The following is a description of a gene set: studied in species Homo sapiens Human Gene Set: GOBP_ENDOLYSOSOMAL_TOLL_LIKE_RECEPTOR_SIGNALING_PATHWAY The series of molecular signals initiated by a ligand binding to an endolysosomal pattern recognition receptor (PRR) of the toll-like family. PRRs bind pathogen-associated molecular pattern (PAMPs), structures conserved among microbial species., and this is the list of marker genes: RAB7B, TNF, UBQLN1, SCARA3, PIK3AP1, TRAF6, HAVCR2, FLOT2, TRIM3, PELI1, DDX3X (NCBI Gene Id 730543), TNFAIP3, PPT1, TLR8, TLR7, NR1H4, TLR3, TIRAP, TNIP2, ZDHHC3, RFTN1, LILRA4, GRAMD4, TICAM1, SCIMP, HCFC2, FLOT1, CAV1, F2RL1, FCRL3, UNC93B1, IKBKB, PTPN22, RTN4, RSAD2, SLC15A4, HMGB1, SRC, RNF170, WASHC4, EPG5, OAS1, TLR9, IRAK1 (interleukin 1 receptor associated kinase 1), TASL, MAP3K7, TREML4, PTPRS, IRAK4, WDFY1, COLEC12, MYD88